Given this list of marker genes Rai2, Hephl1, Thbs3, Ces1a, Ezr, Gabrr1, Ntrk3, Fpgt, Nars1, Cd28, Kif3b, Prrc2c, here is a description of the gene set: Mouse Gene Set: MIR_7020_3P from publication Chen Y, Wang X (PMID 31504780) studied in species Mus musculus Genes predicted to be targets of miRBase v22 microRNA mmu_miR_7020_3p in miRDB v6.0 with MirTarget v4 prediction scores > 80 (high confidence targets).